The following is a description of a gene set: Human Gene Set: MIR7843_5P from publication Chen Y, Wang X (PMID 31504780) studied in species Homo sapiens Genes predicted to be targets of miRBase v22 microRNA hsa-miR-7843-5p in miRDB v6.0 with MirTarget v4 prediction scores > 80 (high confidence targets)., and this is the list of marker genes: REG3G, PARP6, ANKRA2, TSPAN9, COL5A3, TRIM35, KIF21B, ST3GAL5, PUM2, KCNB1, VPS39 (VPS39 subunit of HOPS complex), TLL2, TMEM217, FAM78A, KCND1, SLC6A17, WDTC1, FNDC3B, SRGAP2, NOTCH2, AMOT, FHL1, BCL2L15 (NCBI Gene Id 440603), SLC37A1, TRIM46, NEUROD4, DUSP13A, N4BP1, TRIM4, ERG28, RAB1B, SH3GL2, KLHL14, HNRNPR (NCBI Gene Id 10236), IKZF1, AK3, COL16A1, ADAMTS4, C17orf67, PAX5, TENT4A, DENND11, USP7, KBTBD2, KIAA0513, MAFG, AIF1L, STEAP2, SHOC1, YTHDF3, CECR2, ZNF862, PRMT6, NFYA, DGKK, SMARCD1, MORN5, STK35, RNF19B (NCBI Gene Id 127544), ARHGEF6, CERS3, LSM12, FAM53A, MAP3K11, TRIM26, STAB2, SSR1, WASF2, KCNIP1, PRR32 (NCBI Gene Id 100130613), ATP2B4 (ATPase plasma membrane Ca2+ transporting 4), SLC10A7, PIANP, LDLRAP1, ANKFY1, RTKN, ETV4, ALKBH1, ACVR2B, CHAF1A, RGMB, GOSR2, TMEM201, CDON, TCEA2, SCML1, SOX10, AGO1, CDIN1, RIMS2, XYLT1, PPM1M, SUSD6, NQO1, NOS1, CLIC5, DCX, SATB1, RHBDL1, GABRA4